The following is a description of a gene set: Genes up-regulated in monocytes (12h) versus macrophages (12h) treated with IFNG and TNF. studied in species Homo sapiens Human Gene Set: GSE16385_MONOCYTE_VS_12H_IFNG_TNF_TREATED_MACROPHAGE_UP from publication Szanto A, Balint BL, Nagy ZS, Barta E, Dezso B, Pap A, Szeles L, Poliska S, Oros M, Evans RM, Barak Y, Schwabe J, Nagy L (PMID 21093321) Human CD14 positive monocytes were purified from healthy volunteers’ blood and cultured in vitro for 4, 12, 24, 72 hours. While culturing, macrophages were activated alternatively with interleukin-4 (IL-4 100 ng/ml) or classically with interferon-gamma (IFNg 100 ng/ml)+tumor necrosis factor (TNF 50 ng/ml) or left without activation. Simultaneously, macrophages were also treated with vehicle (DMSO:ethanol) or 1mM synthetic PPARg agonist, Rosiglitazone. We used Affymetrix microarrays (U133Plus 2.0) to analyze activation and PPARg-induced gene expression changes., and this is the list of marker genes: TES, NUBP2, EID1, CAPZA3, CEMIP2, LATS2, DDX28, EID3, HEYL, PSMD1, MCL1, FBXO38, EPB41, TLE3, PSMB5, RPA2, ZMYND19, NAB2, RETREG1 (reticulophagy regulator 1), ZNF32, SAFB, CLEC4D, TMEM248, ST6GAL1, CNTNAP1, RHBDF1, LDLRAP1, RAB5IF, IER3IP1, VGLL3, COMT, KLHL36, ATP1B3, RNPEP, BTD, IGF2BP3, RPL36, FOS, SMN1, CLTA, ELK4, TMEM43, ANAPC16, PDK1, PARP12, MED13L, TLE5, UBR7, KLF13, IPP, PABPC4, GAMT, ZDHHC23, UBOX5, LZIC, GALNT11 (polypeptide N-acetylgalactosaminyltransferase 11), KLF2, STRIP1, ROPN1L, MTA2, YBX1, PLCH2, PPARD, MGAT2, UTP25, ITGB1, DNAJB11, QSOX1, ATP2A2, ZMYND8, PDE12, CENPB (NCBI Gene Id 92501), ART4, L3MBTL3, NDUFAB1, EMC4, KBTBD2, ZNF827, STARD9, LGALS3BP, RHOA, DHDDS, EVL, ELK3, SHROOM1, TMEM35A, EIF5A, UBE2D1, DSTYK, WDR46, PRAMEF8 (PRAME family member 8), GRPEL1, JUNB, PACSIN1, SLC16A1, CYC1, MINDY4, SNRPF, SPA17, HOXA7, FADS2, NCOA7, RPLP2, USP3, KREMEN1, SCML4, TOMM22, LAMA1, TM9SF4, CLPB, BZW2, NSMCE3, UBE2T, LY9, LDLRAD4, FAAH, SEC24D, CTNNBIP1, LY6E, SERP1, UQCC1, CYP24A1, EGR1, ENO2, ZNF689, PPDPF, APMAP, PRR12, ARAP2, SEPTIN9, DTL, PARP1, SLC24A2, YTHDF2, LRIG1, MRPL13, GEMIN4 (NCBI Gene Id 50628), MID1, NSMCE4A, PSMC3, HNRNPD, EGR3, PSMA4, ZFP36, CFL1, CA1 (carbonic anhydrase 1), PTPN22, EGR2, TMEM104, RAB37, SLC35F6, COPB2, RASGRP3, STX19, SOX4, EXOSC2, ZNF358, CHMP2A, GTF2F2, SEC13, PPP1R14B, DPH5, RBM22, ATP5F1B, MRFAP1L1, C6orf141, USP4, CCDC186, CEP170, RARA, RALA, PCDH9, RBM4B, EEIG1, NT5C, POLE3, CARD10, HSP90AB1, BPGM, RBM15B, EIF6, ISCU, NTSR2, ELP5, RRAS2, ARL8A, LIPA, APP, BMP7, SDF4, SNORD104, CD82, TUT1, RECQL4, MAPRE1, CDKN1C, DDX27, NOLC1, IQCH, MRS2